Given this list of marker genes DYNC1I2, KIF24, TMEM67, NEK2, YWHAE, DYNLL1, SDCCAG8, RAB3IP, HAUS4, CEP152, CEP78, CEP89 (NCBI Gene Id 84902), TMEM216, RAB11A, YWHAG, TTBK2, MKS1, SCLT1, CDK1, CC2D2A, DCTN2, HAUS7, C2CD3, HAUS1, NINL, PCM1, ODF2 (NCBI Gene Id 4957), TUBA4A, CEP72, TUBB4A, CEP290, CEP135, CSNK1E, NDE1, RPGRIP1L, CLASP1, CEP97, CCP110, CSNK1D, TCTN1 (tectonic family member 1), MAPRE1, RAB8A, CDK5RAP2, NEDD1, CEP164, TUBB, CEP70, CEP131 (NCBI Gene Id 22994), CEP250, CEP43, DCTN3, DYNC1H1 (dynein cytoplasmic 1 heavy chain 1), B9D1, PRKACA, HAUS8, CKAP5, AKAP9, PLK4, CNTRL, CEP57, ACTR1A, SFI1, HAUS6, TCTN2, NPHP4, FBF1, PLK1, CEP162, AHI1, PRKAR2B, TUBB4B, ALMS1, SSNA1, NPHP1, DCTN1, CENPJ, CEP192, PAFAH1B1, HSP90AA1, CETN2, B9D2, CEP76, PPP2R1A, MARK4, HAUS2, OFD1, TUBG1, CEP63, HAUS5, CEP41, IQCB1, PCNT, TUBA1A, HAUS3, SEPTIN2, TCTN3, CEP83, here is a description of the gene set: species: Homo sapiens Anchoring of the basal body to the plasma membrane Human Gene Set: REACTOME_ANCHORING_OF_THE_BASAL_BODY_TO_THE_PLASMA_MEMBRANE